Given this list of marker genes PTEN (phosphatase and tensin homolog), SDHD, BMPR1A, NTHL1, MSH3, GREM1, APC, SDHB, SMAD4, KLLN, EPCAM, TP53, SDHC, MBD4, ENG, MUTYH, MDM2, POLE, AKT1, CHEK2, USF3, DICER1, CDKN2A, RNF43, MLH1, FLCN, SEC23B, KEAP1, AXIN2, PMS2, PIK3CA, POLD1, here is a description of the gene set: Human Gene Set: HP_LARGE_INTESTINAL_POLYPOSIS Large intestinal polyposis The presence of multiple polyps in the large intestine. species: Homo sapiens